The following is a description of a gene set: The gene expression program underlying the specification of human cell types is of fundamental interest. The study authors generated human cell atlases of gene expression and chromatin accessibility in fetal tissues. For gene expression, the study authors applied three-level combinatorial indexing to >110 samples representing 15 organs, ultimately profiling ~4 million single cells. The study authors leveraged the literature and other atlases to identify and annotate hundreds of cell types and subtypes, both within and across tissues. Our analyses focused on organ-specific specializations of broadly distributed cell types (such as blood, endothelial, and epithelial), sites of fetal erythropoiesis (which notably included the adrenal gland), and integration with mouse developmental atlases (such as conserved specification of blood cells). These data represent a rich resource for the exploration of in vivo human gene expression in diverse tissues and cell types. Marker genes curated from the annotated cluster as represented in the Descartes Human Gene Expression During Development database. Human Gene Set: DESCARTES_MAIN_FETAL_STROMAL_CELLS studied in species Homo sapiens from publication Cao J, O'Day DR, Pliner HA, Kingsley PD, Deng M, Daza RM, Zager MA, Aldinger KA, Blecher-Gonen R, Zhang F, Spielmann M, Palis J, Doherty D, Steemers FJ, Glass IA, Trapnell C, Shendure J (PMID 33184181), and this is the list of marker genes: LINC01412, HSD3BP5, KERA (NCBI Gene Id 1256), LINC01611, CBLN4, COL1A1 (collagen type I alpha 1 chain), MTCH1P2, PI16, THBS2, COL5A1, ENSG00000267284, COL1A2, MEOX2, ITGBL1, MXRA5, COL6A6, RTL3, MIR1245A, COL12A1, ENSG00000272243, LINC01082, LINC00968, SETBP1-DT